Given this list of marker genes ARSL, IARS2, FGFR3, KANSL1, CSPP1, MYH3, PHF6, NFATC2, EXTL3, KIAA0586, TRPM3 (transient receptor potential cation channel subfamily M member 3), here is a description of the gene set: Human Gene Set: HP_CERVICAL_SPINAL_CANAL_STENOSIS studied in species Homo sapiens An abnormal narrowing of the cervical spinal canal. Cervical spinal canal stenosis